Given this list of marker genes BRCA1, FOXO1, BRCA2, GNAS, ESR1, SMAD4 (SMAD family member 4), SMARCB1, GNAI2, AXIN2, SRGAP1, EXT1, TERT, CEBPA, NBN (NCBI Gene Id 4683), IL6, CASP8, IL1B, MYC, PIK3CA, MINPP1, TLR2, SH3GL1, FLCN, KRAS, KIF1B, MCC, RNF6, ERCC6 (NCBI Gene Id 282965, ERCC excision repair 6, chromatin remodeling factor), ACTB, PTEN, TAF15, EGFR, NEK9, TGFBR2, MSH6, BUB1B, NPM1, TP53, MXI1, FGFR1, RHOA, AXIN1, SH2B3, UBA1, MET, ARMC5, MAD1L1 (mitotic arrest deficient 1 like 1), RB1CC1, DCC, IRF1, CALR, BCR, GATA2 (NCBI Gene Id 84724), GPC4, MLLT10, PDGFRA, JAK2, PDGFRL, IL1RN, SMO, GPC3, MYD88, FASLG (NCBI Gene Id 356), TSC2, PPM1D, PIGT (phosphatidylinositol glycan anchor biosynthesis class T), AURKA, PTPN12, NUP214, TFE3, NF1, MPL, PRKN, RB1, RAD54B, TAL1, DLC1, SRC, TSC1 (NCBI Gene Id 7248), WWOX, BRAF (NCBI Gene Id 673), LIG4, ASXL1, POU6F2, ASPSCR1, KLF6, CTNNB1, PIGA, HRAS, WT1, GPR161, MUTYH, ABL1, SF3B1, BARD1, TAL2, ARHGAP26, PTPRJ, PAX7, PICALM, PTCH2, IGF2, BCL10, FLT3, MLH3, CTHRC1 (collagen triple helix repeat containing 1), IDH1 (isocitrate dehydrogenase (NADP(+)) 1), NR4A3, LZTS1, CDC73, RAD54L, PTPN11, HDAC4, NRAS, ZFHX3, CBL, ELP1, ASCC1, OPCML, SLC35A2, FGFR3, PAX3, MSR1, PLAG1, C1GALT1C1, APC, XRCC3, DNMT3A, MAP3K8, PRCC, AKT1, RAD51, GNB1, IGF2R, ATM, RPS14, EWSR1, CHIC2, BUB1, MTOR, CASP10, KIT, CREB1, TET2, SLC22A18, IL6ST, BRIP1, ACVR1B, PLA2G2A, FGFR2, MSH3, AIP, CHEK2, PPP2R1B, CCND1, ETV6, EP300, NQO2, CYP2A6, RUNX1, HMMR, CDH1, DICER1, BAX, PHB1, ADA (adenosine deaminase), SUFU, PAX6, LPP, H19, STK11, ERBB2, RARA, here is a description of the gene set: species: Homo sapiens Description of conditions in which affected individuals typically display somatic mosaicism, i.e., genetically distinct populations of somatic cells in a given organism caused by DNA mutations, epigenetic alterations of DNA, chromosomal abnormalities or the spontaneous reversion of inherited mutations. In many conditions typified by somatic mosaicism, constitutive mutation is lethal and cases are exclusively or predominantly mosaic. Typified by somatic mosaicism Human Gene Set: HP_TYPIFIED_BY_SOMATIC_MOSAICISM